Given this list of marker genes SOX9, SRY, WWOX, MAP3K1, DHX37 (DEAH-box helicase 37), NR5A1, VAMP7, NR0B1, GATA4, WT1, ZFPM2, here is a description of the gene set: Human Gene Set: HP_OVARIAN_GONADOBLASTOMA The presence of a gonadoblastoma of the ovary. Ovarian gonadoblastoma species: Homo sapiens